Given this list of marker genes GLI3, DCHS1, FERMT1, PIGS, SMC3, SRY, FAT4, MEGF8, PRKG2, TBX3, LBR (NCBI Gene Id 653311), GNAS, SHOX, PTCH1, RAB23, FBXL3, FLNA, PORCN, SVBP, here is a description of the gene set: species: Homo sapiens Aplasia or Hypoplasia affecting the 4th metacarpal. Aplasia/Hypoplasia of the 4th metacarpal Human Gene Set: HP_APLASIA_HYPOPLASIA_OF_THE_4TH_METACARPAL